Given this list of marker genes DSTYK, PTDSS1, SGK1, SGPL1, C2orf88, AGTRAP, POLE3, HSPA5 (NCBI Gene Id 3309), PIK3CA, MRGPRF, AMOTL1, RNF31, RNF166, SMAD6, CARD6, CDC42EP3, RXRA, TLE4, KIAA0408, GPSM2 (G protein signaling modulator 2, NCBI Gene Id 29899), ABHD6, SAMHD1, PRP4K, SLA, ERMAP, GBA2, XAF1, SEC13, USP8, MYO1D (NCBI Gene Id 4642), DPY19L1, HIVEP2, FBXO33, SCAMP1, HMGCS1, MYB, PIERCE1, TWF1, RFK, ARHGAP21, FAM241B, ATP6V1G1, PLEKHA5, PITPNM2, TAF12, BMI1, SLC33A1, ARRDC2, MUC20, DCLK1, RNF213, C9orf78, CSNK1G2, PICALM, WEE1, E2F3, TRIP13, PLEKHB2, GALT, IKBIP, TMEM255A, RNF123, FOS, here is a description of the gene set: All metazoan eukaryotes express microRNAs (miRNAs), roughly 22-nucleotide regulatory RNAs that can repress the expression of messenger RNAs bearing complementary sequences. Several DNA viruses also express miRNAs in infected cells, suggesting a role in viral replication and pathogenesis. Although specific viral miRNAs have been shown to autoregulate viral mRNAs or downregulate cellular mRNAs, the function of most viral miRNAs remains unknown. Here we report that the miR-K12-11 miRNA encoded by Kaposi's-sarcoma-associated herpes virus (KSHV) shows significant homology to cellular miR-155, including the entire miRNA 'seed' region. Using a range of assays, we show that expression of physiological levels of miR-K12-11 or miR-155 results in the downregulation of an extensive set of common mRNA targets, including genes with known roles in cell growth regulation. Our findings indicate that viral miR-K12-11 functions as an orthologue of cellular miR-155 and probably evolved to exploit a pre-existing gene regulatory pathway in B cells. Moreover, the known aetiological role of miR-155 in B-cell transformation suggests that miR-K12-11 may contribute to the induction of KSHV-positive B-cell tumours in infected patients. studied in species Homo sapiens from publication Gottwein E, Mukherjee N, Sachse C, Frenzel C, Majoros WH, Chi JT, Braich R, Manoharan M, Soutschek J, Ohler U, Cullen BR (PMID 18075594) Genes down-regulated in BJAB cell line (B lymphocyte) after expression of the viral microRNA miR-K12-11 which functions as an ortholog of cellular MIR155. Human Gene Set: GOTTWEIN_TARGETS_OF_KSHV_MIR_K12_11